Given this list of marker genes Lclat1, Agpat3, Agpat5, Agpat1, Gpat3, Abhd5, Agpat2, Lpcat1, Agpat4, Lpcat2, Pnpla3, Gpat2, here is a description of the gene set: Mouse Gene Set: GOMF_1_ACYLGLYCEROL_3_PHOSPHATE_O_ACYLTRANSFERASE_ACTIVITY Catalysis of the reaction: acyl-CoA + 1-acyl-sn-glycerol-3-phosphate = CoA + 1,2-diacyl-sn-glycerol-3-phosphate. species: Mus musculus